Given this list of marker genes CPSF6, RPA1, SFPQ (NCBI Gene Id 6421), NCL, ZCCHC8, SRSF2, DEK, HNRNPK, HNRNPR, SNRPD3, HNRNPU, PAPOLA (poly(A) polymerase alpha), RBMX, SRI, XPO1, HNRNPAB (NCBI Gene Id 3182), MAGOH, DHX15, U2SURP, SRSF3, EXOSC8, NUP153, TDG, HNRNPM, HNRNPA3P1, EIF3A (NCBI Gene Id 8661), PTBP1, TARDBP, PTGES3, TRA2B, SERBP1, PDS5A, SRSF1, SUMO2, CBX3, here is a description of the gene set: Neighborhood of TDG Human Gene Set: GNF2_TDG Neighborhood of TDG thymine-DNA glycosylase in the GNF2 expression compendium studied in species Homo sapiens